Given this list of marker genes KCNC4, C22orf31, SLC5A3, GLRX3, WNT5A, GLRA3, NR2C2, PSG9, PRDM1, PLA2G6, PRG4, GHRHR, FUT5, COL9A3, HSPB6, PRSS12, FZD7, TNFSF14, GFRA1, ADTRP (androgen dependent TFPI regulating protein), SLC22A14, CNMD (chondromodulin), PAK3, CTSV, GPER1, UGT2B10, SLC1A3, PDLIM3, IGF2, SLC38A3 (NCBI Gene Id 10991), STK11, PNLIP, GBA1, FOXE1, WASF3, AQP4, CKMT1B, S100G, DEPDC5, OPRM1, COX7A1, RIN1, EPHA7, MGAM, ERBB2, FOXD2, GPC4 (glypican 4), PCDHGA8, SEMG1, SOX21, COMP, ENDOG, MMP13, CACNB4, STC1, CCL8, ID4, ABCB6, SLC6A1, FSCN2, PRPH2, BDNF, MAPK12 (NCBI Gene Id 6300), STRN, CEBPE, MMP14, SCAND2P, ETV1, GABRR2, CLEC4M, C8G, AFP, EPN2, COL11A1 (NCBI Gene Id 317718), TGM5, FCER2, EPHA4, RGS20, CHKA, KIR2DL4, ATP2A1 (ATPase sarcoplasmic/endoplasmic reticulum Ca2+ transporting 1), TGM1, TBX6, TMPRSS15, SLC22A1, PDE9A, PSTPIP1, CRHBP, LALBA, ARSB, AGRP, LOXL1, PTPRS, ATP1A2, GLS2, KCNS1, SLC18A2, BFSP2, KRT76, FZD1, VIPR2, CCR6, APBB1, EPHX1, EFNA4, BBOX1, OXT, FANCC, NEUROD1, ALOX15B, HOXC6, KCNA3, CLCA2, CA6, COL4A1, GAST, CSN1S1, CADM4, CROCC, RNASE4, CAPN11, KCNV2 (NCBI Gene Id 169522), GSTM3, CLCN2, GRB14, CLCNKB, LAMA2, KCNA1 (NCBI Gene Id 729214), E2F2, SSPN, VILL, PPP1R3A, CAMK1G, GOLIM4, KLF5, INSL4, LPAR1, NR2E1, MAD1L1, SERPINB7, FGF6, WNT8B, FETUB, NEFL, PCK1, FASLG, KCND1, ADH1B, SNN, XCL1, AGTR2, RAMP1, LEPR, PKP1 (NCBI Gene Id 5317), PDYN, NCAM2, SCRG1, CYP7A1, GABRG3, CCDC106, CD101, CHRNA2, MS4A2, EMX2, CRLF1, ADAMTS2, TRIM9, ADORA1, GULP1, TNFRSF8, FGF7, THBS2 (thrombospondin 2), RFX3, FBXL7, CYP27A1, UGT8, PYY, IFI6, PFKFB1, CRYGA, LZTS3, C14orf132 (chromosome 14 open reading frame 132), CGA, RARB, OTC, ELOVL6, COL13A1, TNC, SYN3, H3C10, PPARA, ERBB4, USH2A, LGALS2, IL9, AIRE, LIFR, OMD (osteomodulin), GAGE12G, GBX2, RAPGEF1, MAGEB1, ZNF365, SFRP1, SNCG, PTAFR, HSPA1B (heat shock protein family A (Hsp70) member 1B), SLC6A3, NAP1L3, SCGB2A1, DGKE, AFM, TADA2A, CHRNA5, HTN3, FGFR2 (NCBI Gene Id 2263), IL12RB1, RPE65, CROT, SLC22A18, CD2BP2, H1-1, MYH8, SPINK4, CYP2B6, ZFHX2, RIT2, MSH4, CCR5, FN1, KCNB2, KAZALD1, NRP1, GPC5, SLC7A8, BMPR1B, BCHE, ABLIM3, SLC26A10P, PLA2R1, IGF1, NKX2-5, TRPC6, FSTL3, RPL3L, RFPL1, DNASE1L2, MEIS2, AMPD1, ADAMDEC1, CTNNA2, RPL39L, LHCGR, F5, TLL1, TMPRSS11D, CXCR2, ANK2, NCAM1, NRG1, POU4F2, CFH, LYPD1, CHRNA3, TCP10L3, SSX1, PPP1R2C, HP, MEP1A, CREB5 (cAMP responsive element binding protein 5), SLC16A4, ABCD1, ASL, FZD9, CFHR1, FILIP1L, SLC30A4, ADAM2, GNRH1, RNF8, MSI1, HNF1A, PDGFRL, ETS1, NR5A2, MEOX1, KIR3DL1, SV2B, CCN5, MARCO, REM1, LAMP3, CCL22, KCNK2, F11, GTF2A1, IFNA21, SLC26A3, GZMM, AKAP6, ANGEL2, TNK1, CCL1 (NCBI Gene Id 6346), GPRC5B, CNTFR, IBSP, TULP2 (TUB like protein 2), SPOUT1, CDR1, IL11, VNN2, ADCY8, B4GALT5, EML1, CLGN, GJC2, PAPSS2, MMP3, FHL2, CNTN5, HSD17B2, MAGEB2 (MAGE family member B2), H3C11, BTN1A1, FER, GPR39, B3GALT5, NAT2, KCNE1, SERPINB3, LAMA4, GNAT2, CBR3, MYH11, OVOL1, TLX1, ABAT, PDE1A, SULT1C2, RGS13, DLG3, CTSZ, CCR9, ARSG, KCNB1, PLPP2, SERPINI2, MMP20, SLC10A1, STAM2, ARL4D, KIF5A, GH2, PRKCA, GUCY1A2, GLI3, CASK, here is a description of the gene set: Genes in the cancer module 99. Human Gene Set: MODULE_99 species: Homo sapiens